The following is a description of a gene set: from publication Chen Y, Wang X (PMID 31504780) Human Gene Set: MIR3117_5P studied in species Homo sapiens Genes predicted to be targets of miRBase v22 microRNA hsa-miR-3117-5p in miRDB v6.0 with MirTarget v4 prediction scores > 80 (high confidence targets)., and this is the list of marker genes: ZSWIM6, BICD2, EIF3H, ZNF500, STAT5B, CLEC12B, SCEL, RCHY1, SLC16A1, MRPS6, CDK8, GPAT3, PTCHD1, CAPZA2, PCDH17, SESN3, RBCK1, HIPK3, ITPKB, ZNF235, SEC24A, ARMCX3, ZNF587B, RIT1 (Ras like without CAAX 1), KRAS, KATNBL1, FASTKD3, NF1, SLC5A3 (NCBI Gene Id 6526), PTPRZ1 (NCBI Gene Id 7983), TRIM43, MYRIP, MICAL2, DDX46, FAT1, MAPK9, ADSS1, VRK2, PCDHB5, MBNL1, CAPZA1, ERC1 (ELKS/RAB6-interacting/CAST family member 1), RHPN2 (NCBI Gene Id 85415), MED14OS, INPP4A, RCOR1, TCF12, FAM124B, IL36G, CNEP1R1, DDX17, NCAM1, ANKRD34B, SGCD, GRM8, SLC25A48, RTN4IP1, LYPD5, UBQLN1